Given this list of marker genes Cntln, Pcdh10, Eaf1, Slc12a6, Slc7a1, Man1c1, Srsf10, Cul3, Gpr3, Celsr3, Ep300, Esrp1 (NCBI Gene Id 70076), P2rx7, H13, Homer2, Lca5, Dscaml1, Ppp1r26, Bltp2, Trmt2a, Dclk1, Acbd4, Cacnb4, Vax1, Nudcd3, Map3k3, Anks1, Otulinl, A630001G21Rik, Rarb, Acvr1, Zfp628, Trim12c, Ola1, Negr1, Ube2d2a, Tmtc3, Kctd15, Ythdf1, Spred3, Tiparp, Rnf152, Sacs (NCBI Gene Id 50720), here is a description of the gene set: from publication Chen Y, Wang X (PMID 31504780) Genes predicted to be targets of miRBase v22 microRNA mmu_miR_193a_5p in miRDB v6.0 with MirTarget v4 prediction scores > 80 (high confidence targets). studied in species Mus musculus Mouse Gene Set: MIR_193A_5P